The following is a description of a gene set: The transcription factor FoxP3 partakes dominantly in the specification and function of FoxP3+ CD4+ T regulatory cells (Tregs), but is neither strictly necessary nor sufficient to determine the characteristic Treg transcriptional signature. Computational network inference and experimental testing assessed the contribution of several other transcription factors (TFs). Enforced expression of Helios or Xbp1 elicited specific signatures, but Eos, Irf4, Satb1, Lef1 and Gata1 elicited exactly the same outcome, synergizing with FoxP3 to activate most of the Treg signature, including key TFs, and enhancing FoxP3 occupancy at its genomic targets. Conversely, the Treg signature was robust to inactivation of any single cofactor. A redundant genetic switch thus locks-in the Treg phenotype, a model which accounts for several aspects of Treg physiology, differentiation and stability. Human Gene Set: GSE40274_CTRL_VS_FOXP3_TRANSDUCED_ACTIVATED_CD4_TCELL_DN Genes down-regulated in CD4 T conv: control versus over-expression of FOXP3. species: Homo sapiens from publication Fu W, Ergun A, Lu T, Hill JA, Haxhinasto S, Fassett MS, Gazit R, Adoro S, Glimcher L, Chan S, Kastner P, Rossi D, Collins JJ, Mathis D, Benoist C (PMID 22961053), and this is the list of marker genes: GIMAP4, CYB561A3, ELAC1, HSD17B11, SERPINI1, ABHD17B, ZKSCAN5, SDC4, ARHGAP24 (Rho GTPase activating protein 24), ZNF274, RCAN1, KMT2E, CKAP4, MAU2, NPC1 (NCBI Gene Id 4864), EEF2K (NCBI Gene Id 29904), C3orf33, MAN1A1, NUCB2, ST8SIA6, SPATA6, CD200, SNRNP70, IRAK3, GPCPD1, UBL3, ST8SIA4, JARID2, KLHL14, MED12, GIMAP8, NID1, TLR7, KLHDC1, ITM2B, GBP7, LPCAT2, ANXA6, KLF2, SEMA4B, RIGI, FAM168A, NIBAN3, IKBKB, ZMYM5, RNF13, RMC1, RPL13, DOCK11, FOXO3, HLA-B, MFSD8, CCPG1, MAF1, S100A10, IFNAR2, NCF1 (NCBI Gene Id 653844), DPP4, RSRP1, CAPG, MGAT4A (NCBI Gene Id 11320), CD81, IL27RA, ESYT1, HEXA, GNE, RHOA, RDX, TRIM25, CNN3, CHD2, SNN, ARL13B (NCBI Gene Id 200894), GPR18, LY6D, TMOD3, FILIP1L, BTG3, SLC10A3, MAPK12, CTSC, KCTD14, FAM43A, B3GNT5, GIMAP7, RIPOR2, ABCG1, TMEM154, IRGM, KCTD6, PIP4P1, ZNF182, DSTYK, ARID5B, KCTD12, DDIT4, PARP14, ARHGAP45, SGK1, ST3GAL1, ADM, PISD, RILPL2, ARMC7, LGALS3, MYO1H, GM2A, MYLIP, SBK1, RRBP1, CYP4F3, MXI1, KLF7 (NCBI Gene Id 8609), H6PD, SAMD9L, ABCA1, MFHAS1, RASSF5 (Ras association domain family member 5), MYCBP2, KDM7A, ITGB7, FUS, ARHGEF18, MALAT1 (NCBI Gene Id 378938), ITGA4, RSU1, SERINC3, ZNF445, ATF7IP (NCBI Gene Id 55729), PCMTD2, TMEM176A, PLBD1, SSPN, PTPN22, SELPLG, LRIG2, MAP3K1, IFT140, AFF3, ATXN1, ADGRE5, FPGT, SLC66A2, PATJ (PATJ crumbs cell polarity complex component), MICALL1, ALKBH2, C5orf34, GNS, EVI2A, ARHGEF3, BACH1, TRIM7, CLN5, LPCAT1, EMP3, MYSM1, CBR1, P2RX4, KYNU, CD300LF, GAN, FBXL12, USP3, EVI2B (NCBI Gene Id 2124), SLC25A37, ZMYND11, CD1D, RNASEL, ARSK, TET2, GPR183 (G protein-coupled receptor 183), MBLAC2, VIM, ATP10D, TCN2, GPR65, ADD1, FOXJ2, TMEM140, CYRIA, CCR7, TBC1D5, IKBIP (IKBKB interacting protein), ZNF467, FYCO1, ZBTB18, CALHM2, CD38, PSAP, TK2, SNAP47, IFNGR2, ITPR1, HLA-E, SATB1, RASGRP2, LGALS8, PSTPIP1, CCR6 (C-C motif chemokine receptor 6), KDM5B